The following is a description of a gene set: Human Gene Set: GALE_APL_WITH_FLT3_MUTATED_UP studied in species Homo sapiens from publication Gale RE, Hills R, Pizzey AR, Kottaridis PD, Swirsky D, Gilkes AF, Nugent E, Mills KI, Wheatley K, Solomon E, Burnett AK, Linch DC, Grimwade D, NCRI Adult Leukaemia Working Party (PMID 16105978) Genes up-regulated in acute promyelocytic leukemia (APL) patients with mutated FLT3. The prognostic significance of FLT3 mutations in acute promyelocytic leukemia (APL) is not firmly established and is of particular interest given the opportunities for targeted therapies using FLT3 inhibitors. We studied 203 patients with PML-RARA-positive APL; 43% of the patients had an FLT3 mutation (65 internal tandem duplications, 19 D835/I836, 4 ITD+D835/I836). Both mutations were associated with higher white blood cell (WBC) count at presentation; 75% of the patients with WBC counts of 10 x 10(9)/L or greater had mutant FLT3. FLT3/ITDs were correlated with M3v subtype (P <.001), bcr3 PML breakpoint (P <.001), and expression of reciprocal RARA-PML transcripts (P =.01). Microarray analysis revealed differences in expression profiles among patients with FLT3/ITD, D835/I836, and wild-type FLT3. Patients with mutant FLT3 had a higher rate of induction death (19% vs 9%; P =.04, but no significant difference in relapse risk (28% vs 23%; P =.5) or overall survival (59% vs 67%; P =.2) at 5 years. In in vitro differentiation assays using primary APL blasts (n = 6), the FLT3 inhibitor CEP-701 had a greater effect on cell survival/proliferation in FLT3/ITD+ cells, but this inhibition was reduced in the presence of ATRA. Furthermore, in the presence of CEP-701, ATRA-induced differentiation was reduced in FLT3/ITD+ cells. These data carry implications for the use of FLT3 inhibitors as frontline therapy for APL., and this is the list of marker genes: CSNK1A1, AHI1, SLC46A3, LANCL1, SOCS2, GIMAP6, PLAGL1, TRMT11, INPP5F, HNRNPH1, TTK, AVL9, FANCI, MIS12, ATF6, ABCC1, LUC7L3, TELO2, ZNF529, SMG1P5, CFH, PIGB, LARS2, STX16, CDC16, RFC3, MYO1B (NCBI Gene Id 92451), APOBEC3B, HTATIP2, TRMT61B, RNF144A, PHF11, DHX15 (NCBI Gene Id 1665), TCF12, PMM2, SLC25A13, RFTN1, NOLC1, HEATR1, CHD9, RRAS2, GEMIN4, RITA1 (NCBI Gene Id 84934), LYPLA1, ELF3, DELE1, VPS54, PSMF1, NSL1, WIPF1, UNC119B, MTMR1, ATR, UPF3A, KPNB1, ARHGAP45, SRSF11, C6orf62